Given this list of marker genes NCOR1 (nuclear receptor corepressor 1), PLK2, RGSL1, PLEKHA8, JADE1, DNAJA2, PPM1H, LNX2, PPM1M, PLXDC2, SDC3, PCDH11X, FBXL16, SBF1, FXYD6, NKAIN2, LARP1, GRAP2, RAB22A, ZNF609, EEF1AKMT4, PDE4D, HAGH, ZFAND5 (zinc finger AN1-type containing 5), PTPRF, MMAB, SETBP1, PHF11, POLR2D, MORF4L2, LRRC32, MSANTD3, PPME1, STK40 (NCBI Gene Id 83931), SRY, USP9X, TXLNG, FBXW10B, PRPF38A, PCBP3, MBTD1, ADCY1, ZNF410, MAGI1, TAB2, here is a description of the gene set: Human Gene Set: MIR4675 studied in species Homo sapiens from publication Chen Y, Wang X (PMID 31504780) Genes predicted to be targets of miRBase v22 microRNA hsa-miR-4675 in miRDB v6.0 with MirTarget v4 prediction scores > 80 (high confidence targets).